Given this list of marker genes Zscan12, Nop58, Hexd, Zfp280c, Ccdc9, Ptpn21, Sptan1, Psip1, Cdc6, Cops7a, Utp25, Pold2, Mrpl50, Rbl1, Mad2l2, Zbtb22, Wac, Abce1, Txnip, Tns2, Pole, Cnn3, 2310061I04Rik, Cdc73, Zfp386, Iars1, Zfp329, Nsmce4a, Uba3, Bnip1, Kri1, Dhx36, Klf6, Wdr82, Zfp142, Gorasp2, Peak1, Pelp1, Eif4b, Cyb5b, Stx8, Vamp3, Sfxn1, Cip2a, Pbx2, Taf1d, Mtap, Gna12, Dsg2, Pold3, Keap1, Rita1, Eef1e1, Socs2, Txnrd3, Dars1, Gcsh, Enc1, Zfp68, Slc39a3, Tbc1d19, Aatf, Taf8, Rcl1 (NCBI Gene Id 98135), Arpc1b, Oxsm, Ap1g1, Nudt16l1, Enox2 (NCBI Gene Id 209224), Cdk2, Rrm1, Cdca7, Cpne1, Dmac2, Tmem186, Senp1, Rhbdd1, Kat2a, Map2 (microtubule-associated protein 2), Fjx1, Phip, Phykpl, Ppp4r3a, Mrrf, Foxm1, Suox, Mrps5, Ncapg2, Lpcat1, Dusp11, Eif4e2, Ache, Bcs1l, Adam17, 2010204K13Rik, Adissp, Exosc5, Lrrc8c, Fam220a, C1qbp, Syncrip, Cetn3 (centrin 3), Arhgap5, Luc7l2, Tbl2, Il6st, Zik1, Ppil4, Snrnp40, Tars2, Mtbp, Ehd2, Mdp1, Borcs7, Arf6, Dnajc14, Dcaf1, Mospd2, Loxl4, Erbb2, Foxj3, Hspa9, Pex11a, Zfp644, Smarce1, Ccl5, Kpna3, Agfg2, Bccip (BRCA2 and CDKN1A interacting protein), Cbx1, 1810030O07Rik, Stambpl1, Traf6, Dhps, Prmt2, Srsf2, Dbn1, Eif4a1, Hjurp, Polr2i, Dimt1, Pigu, Ube2g2, AI506816, Tbrg4, Ptrhd1, Rpl41 (ribosomal protein L41), 4833420G17Rik, Trip4, Trip13, Fer, Tomm5, Akap8, Timm9, Ophn1, Pofut1, Lig3, Zdhhc6, Slc23a2, Aldh18a1, Exosc2, Wdfy3 (NCBI Gene Id 72145), Grtp1 (NCBI Gene Id 97461), Hnrnpdl (NCBI Gene Id 52396), Tcf7l2, Krba1, Etaa1, Ercc4, Mmgt2, Ptbp3, Zfand3, Hmga2, Fastkd2 (NCBI Gene Id 75619), Mbd3, Faim, Shkbp1, Rfxank, Paics, Smyd5, Pum3, Raver1 (ribonucleoprotein, PTB-binding 1), Slc46a1, Flot1, Yes1, Pld2, Zbtb12, Timm10, Nolc1, AU020206, Mtmr2, Runx2 (runt related transcription factor 2), Abcc1, Nasp, Cd2ap (NCBI Gene Id 98065), Vti1a, Chmp1b2, Gtpbp2, Mthfd2, Fndc4, Bcl3, Ifrd2, Nras, Nfic, Brd8, Gnl1, Mynn, Fam118a, Suv39h1, Ddx10, Nr1d2, Osbpl9, Mutyh, Lancl2, Thsd1, Phf21a, Rps19-ps3, Srsf7, Bclaf1, Galk1, Zbed3, Nf2, Cpt1b, Arl6ip5, Opa3 (NCBI Gene Id 403187), Exosc1, Ppih, Erc1, Hspa8, Coa7, Wdr13, Csde1, Hspbp1, Trp53i13, Psmg1, Vasp, Dazap1, Nfib, Coil, Fkbp11, Pex14, Btn1a1, Ibtk, Spag7, Hmbs, Rab4a, Snhg5, Ssr1, Uri1, Timeless, Cd200, Usp4 (NCBI Gene Id 22258), Frmd4b, Trmt112, Mllt10, U2af1l4, Nelfa, Bcl2l2, Dpagt1, Rpl3 (ribosomal protein L3), P2rx4, Hcfc1, Tubb2b, Taok1, Cep152, Rab3d, Nop56, Vti1b, Pqbp1, Slc4a3, Mbd2, Slc9b1, Cyp2c55, Gemin6, Tmem60, Gmfb, 2310030G06Rik, Hps1, Klhl7, Cela1, Coq5, Actb, Toe1, Polr3a, Slc35a3, Cstf2, Mrpl32, Mybbp1a, Nipsnap3a, Fxn, Rrp15, Ccdc43, Notch4, Dtx3, Mtf2, Hivep3, Bcl9, Tctn3, Mrpl19, Slc25a10, Cttn, Wdr75, Poli, Cd44, Tmem268, Abcb7, Nup58, Tspan2, Lbr, Ptrh2, Pnn, Atp5f1c, Ndufaf4, Steap4, F2rl1, Elp2, Dynlt1b, Gpr35, Sp3, Rpl30, Magohb, Kics2, Foxk2, B230354K17Rik, Rpp40, Cxcl5, Hnrnpl, Msh3, Trim16, Sfr1, Lmbr1, Prpf39, Pias2, Lyplal1, Scamp4, St13, Zfp292 (NCBI Gene Id 77306, zinc finger protein 292), Tubb5, Plscr1, Ccl20, Ate1, Adat2, Rad23b (RAD23 homolog B, nucleotide excision repair protein), Epb41l2, Rab4b, Nectin2, Tmem216, Ube2s, Zkscan3, Spdef, Pcdhb21, Epn2, Pabpn1, Dmac1, Fermt2, Nsmce1, Gys1, Usp22, Ccsap, Bbs9, Bloc1s5, Rad51c, Srsf10, Wdr4, Kpnb1, Mettl1, Bnip3l, Srsf6, Cyp1b1, Tmem161a, Nr2c1, Acin1, Got1, Faah, Ears2, Ess2, Morf4l2, Neurl4, Osmr, 1810009A15Rik, Pipox, Gdpd1, Cdk5rap1, Dusp12, Mcm2, Apbb1, Lmnb2, Khdrbs1, Cnot6, Nsfl1c, Anapc4, Hnrnpa1, Cptp, Gtf2ird1, Uqcc4, Exosc10, Erg28, Tcof1, Chd1l, Ogt, Zdhhc3, Brat1, Elk1, Snhg6, Eps8l3, Stam2, Rp2, Rusf1, Pdha1, Cstf3, Sfn (NCBI Gene Id 55948), Tfap4, Slc39a11, Sgtb, Phf12 (NCBI Gene Id 76807), Nop10, Ap3m2, Ttc8, Atxn7l3, Cyp4f13, Trub2 (TruB pseudouridine (psi) synthase family member 2), Pomk, Trdmt1, Dhcr24, Nup133, Sin3a, Dctpp1, Rpp14, Norad, Plekhf1, Casc3, Ubap2l, Il15ra, Zfp101, Apex1, Trib3, Dtnbp1, Adamtsl5, Cdkal1, Tcf3, Zmym6, Ints7, Xpo4, Grhl2, Mt1, Bet1, Plk4, Hells, Pcid2, Trip11, Trib1, Polr1a, Myc, Vsx2, Tk1, Ip6k1, Polr1has, Ccn5 (NCBI Gene Id 50503), Rbm10 (NCBI Gene Id 260306), Minpp1, Cfap298 (cilia and flagella associate protien 298), Sec14l1, Slc9a8, Ppp2r1b, Timp3, Sarnp, Stk3, Far1, Ywhaz, Dhx9, Zfp111, Adck1, Polr3f, Vps54, Tom1l1, Eef1akmt1, Il13ra1, Pcgf2, Polb, Timm44, Tpbg, Pak3, Coq3, Foxp1, Rnf214, Ppp1cc, Smr2, Mdn1, Zdhhc5, Sec24d, Ier3, Traf2, Clcf1, Zfp82, Hdac7, Stat5a, Cox17, Mmachc (methylmalonic aciduria cblC type, with homocystinuria), Snx5, Pdgfra, Tcp1, Sox6, Ppp2r3a, 1700030K09Rik, Zfp207, Acvr1b (NCBI Gene Id 328611), Fto, Nudcd1, Cilk1, Yae1d1, Pabir1, Mettl22, Map2k7, Dcaf8, Slc25a13, Skp2, Chac2, Krcc1, Rfc1, Ska1, Atf4, Pigo, Polr1h, Zfp422, Jtb (jumping translocation breakpoint), Dgcr2, Pot1a, Fbxw2, Heatr1, Vps72, Mapk3, Ipo8 (importin 8), Elac1, Rabggtb, Dhdds, Tcerg1, Mrpl58, Foxn2, Farsb, Ube2j1, Notch2, Ivns1abp, Ror1, Map3k4, Pmf1, Stard4, Deptor, Atf6, Pus3, Zfp771, Pard6b, Dph6, Tril, Rgs19, Rabif, Cnep1r1, Rad23a, Papola, Il1r1, Dnajb12, Ptprs, Psmg4, Mrpl12, Cebpg, Pou2f1, Supt20, Dtl, Hmbox1, Numb, Exoc6, Nkd2, Hip1, Tbc1d17, Rbbp9, Parp2, Cat (catalase), Mdfi, Bysl, Spen, Nt5e, Mrpl3, Pcnx3, Tmem126a, Ikbkb, Cnot2, Rhou, Rlim, Ube2d3, Psmd11, Xpr1, Zscan22, Pdss1, Cdk16, Cbx3, Nck2, Adat1, Cyb5r1, Caprin1, Immt, Wdr77, Sh3rf1, Tpm3, Snord22, Pold1, Ptprf, Kitl, Pagr1a, Glycam1, Spin1, Gnpnat1, Fancm, Stat5b, Rbm39, Spop, Csnk1d, Etf1, Runx1, Pmpcb, Cfap97, Seh1l, Snrnp48, Tars1, Srprb, Plp2, Rfk, Tmem168, Map4k5, Fstl1, Nicn1, Sinhcaf, Socs6, Fubp1, Ldlr, Cep41, Tyms, Ripk1, Naa15, Golph3, Hspa4, Ryk, Rassf1, Dcp1a, Tmem209, Mphosph10, Phka1, Dtymk, Tmpo, Zfp277, Tmem167, Commd2, Fignl1, Rrp8, Ensa, Gas5, Mga, Smim10l1, Ccdc102a, Herc4, Pigp, Rufy3, Fbxw11, Pik3c3, Rccd1, Me2, Tia1, Gmnn, Marcksl1 (MARCKS-like 1), Gatb, Dgcr8, Bpnt1, C1d, Ilf3, Rai14, Arid4b (NCBI Gene Id 94246), Thop1, Usp34, Mccc2, Cebpb, Polr1b, Gdi1, Srsf1, Dhodh, Tti2, Use1, Slc29a2, Ocel1, Zeb2, D2hgdh, Usp36, Eid1, Ddx19b, Med16, Ptdss2, Elac2, Hibch, Gcnt1, Klhl20, Trmt1l, Twf1, Nubp1, Cgnl1, Rpp21, Rusc2, Vangl2, Gpam, Bcl7b, Zfp212, Tpk1, Srek1, Orc3, Eri2, Tfrc, Gfpt1, Exosc7, Ipp, Snapin, Arhgef10, Armcx1, Irf3, Rce1, Gsr, Zbtb14, Rnaseh1, Nxt1, Chd4, Csnk2a1, Cnot7, Kmt5b, Ccnq, Dcps, Sc5d, Ankrd28, Snhg16, Psenen, Ppdpf, Dctn4, Msn, Klhl5, Myg1, Fosl2, Eif4a2, Acbd6, Nfyc, Btbd3 (NCBI Gene Id 228662), Ghdc (NCBI Gene Id 80860), C1qtnf12, Mthfs, Tsen15, Dram2, Pbk, Tefm, Prkd3, Zcchc8, Nt5c3b, Alg3, Plekhg5, Ssbp1, Zfp768, Lmf1, Sema6d, Yeats4, Czib, Gart, Hmgxb4, Tmem39a, Dnm1l (dynamin 1-like), Akap12, Tdp1, Erlin1, Nutf2 (NCBI Gene Id 68051), Nisch, Prpf31, Rilpl2, Ppat, Zfp790, Eif2s2, Rbm18, Ercc6l2, Vrk3 (vaccinia related kinase 3), Arglu1, Itga5, Tomm40, Nherf2, here is a description of the gene set: studied in species Mus musculus Genes down-regulated in ME-A cells (breast cancer, sensitive to apoptotic stimuli) exposed to doxorubicin in the presence of medium concentrate (MC) from ME-C cells (breast cancer, resistant to apoptotic stimuli). Mouse Gene Set: GRAESSMANN_RESPONSE_TO_MC_AND_DOXORUBICIN_DN from publication Graessmann M, Berg B, Fuchs B, Klein A, Graessmann A (PMID 17160024) Impairment of the complex regulatory network of cell death and survival is frequently the reason for therapy resistance of breast cancer cells and a major cause of tumor progression. We established two independent cell lines from a fast growing mouse breast tumor (WAP-SVT/t transgenic animal). Cells from one line (ME-A cells) are sensitive to apoptotic stimuli such as growth factor depletion or treatment with antitumor agents (e.g. doxorubicin). Cells from the second line (ME-C cells), which carry a missense mutation at the p53 codon 242, are very insensitive to apoptotic stimuli. Co-cultivation experiments revealed that the ME-C cells mediate cell death resistance to the ME-A cells. Microarray and Western blot analysis showed that osteopontin (OPN) is selectively overexpressed by the ME-C cells. This glycoprotein is the most abundant protein secreted by the ME-C cells and we obtained strong indications that OPN is the main antiapoptotic factor. However, the OPN containing ME-C cell medium does not alter the expression level of pro- or antiapoptotic genes or known inhibitors of apoptosis (IAPs). Its signaling involves mitogen-activated protein kinase (MAPK)/extracellular signal-regulated kinase (ERK) kinase (MEK)1/2 as the kinase inhibitor PD98059 restores apoptosis but not the Akt inhibitor. In the ME-A cells, mitochondrial cytochrome c release occurs with and without external apoptotic stimuli. OPN containing ME-C cell medium does not prevent the mitochondrial cytochrome c release and caspase-9 processing. In serum starved ME-A cells, the OPN containing ME-C cell medium prevents caspase-3 activation. However, in doxorubicin-treated cells, although apoptosis is blocked, it does not inhibit caspase-3. This indicates that the ME-A cells distinguish between the initial apoptotic stimuli and that the cells possess a further uncharacterized control element acting downstream from caspase-3.